Given this list of marker genes Sema3a, Sult4a1, Grip1, Cntnap2, Igf2bp1, Ptn, Nrp1, Taok2, Phactr1, Chrna7, Tpbg, Zfp365, Atg16l1, Cc2d1a (NCBI Gene Id 212139), Afdn, here is a description of the gene set: Mouse Gene Set: GOBP_DENDRITE_ARBORIZATION species: Mus musculus The process in which the anatomical structures of a dendritic tree are generated and organized into dendritic branches.